Given this list of marker genes Rad21, Trim37, Hnrnpc (NCBI Gene Id 28125), Prdx2, Gsk3a, St3gal4, Kitl, Racgap1, S100a3, Mki67, Prim1, Prc1, Slc39a6, Nipbl, Ect2, Gas6, Vamp5, Snhg5, Nsmce4a, Fubp1, Amd1, Asf1b, Tfdp1, Grem2, Cdt1, Cmc4, Cpsf2, Rcl1, Luc7l3, Nucks1, Pspc1 (paraspeckle protein 1), Btbd1, Anapc5, Ahcyl, Smc3, Cenpk, Kif2c, Adsl, Cdca7l, Brip1os, Kif20a, Psip1, Cdca3, E2f8, Ptges3, Hmgb3, Epb41l4aos, Cdc45, Vcan, Hmgn2, Gclc (glutamate-cysteine ligase, catalytic subunit), Trim59, Id4, Ptgis, Dnph1, Hjurp, Iqgap3, Pclaf, Cks1b, Parp1, Birc5, Haus3, Ptprv, Ptma, Col6a3, Brca1, Rbbp4, Mre11a, Alad, Tsc22d1, Scoc, Mdm2, Aurka, Casp8ap2, E2f1 (E2F transcription factor 1), Gm3325, Hmgn1, Tmem106c, Hmga2 (high mobility group AT-hook 2), Cav1, Perp, Cbx5, Brca2, Ei24, Myh11, Tpgs2, Tk1, Anln, Dlgap5, Gm4870, Cenpa, Ppp5c, Nav2, Zmynd11, H2az1, Anapc11 (NCBI Gene Id 97770), Prrx2, Fignl1 (fidgetin-like 1), Hip1r, Cip2a, Cdk2, Dek, Crip2, Lmo7, Tubb5, Gmnn, Mad2l1, Rbmx, Prpf19, Smc2, Idh2, Sema3c (NCBI Gene Id 68696), Lsm3, Etfb, Tardbp, Pdia3, Tulp4, Garin5b, Orc6, Sfpq, Pabpc4, Tmpo, Kank3, Dctpp1, H19, Helb, Kif11 (kinesin family member 11), H2az2, Ptger4, Kpna2, Ephx1, Mir5136, Hat1, Igf1r, Rfc1, Set, Fbln1, Mcm7 (NCBI Gene Id 17220), Mis18bp1 (NCBI Gene Id 97807), Kif2a, Hypk (NCBI Gene Id 67693), Has1, Dtymk, Anp32b, Cd34, Cxcl1 (C-X-C motif chemokine ligand 1), Mcm5, Ccnf, Cse1l, Naa10, Tiparp, Wwtr1, Fam13b, Nqo1, Tipin, Hpf1, Erdr1, Ramp3, Dnajc9, Pradc1, Ipo5, Lsm4, Tnrc6a, Prl2c2, Kif4, Cck, Dohh, Ube2t, Arcn1, Otud4, Il1r1, Fas, Dlx1, Plk1, Bub1, Cbx6, Ifrd2, Mcm4, Ranbp1, Chaf1b, Ces2g, D17H6S56E-5, Cebpz, Klf10, Spdl1, Slc12a2, Cdc25c, Ogt, Rbl1, Kif23, Hspd1, Xpo1, Rfc5, Dstn, Ilf3, Cdc6 (cell division cycle 6), Hdac2, Ccnb2, Wac, Nop58, Ylpm1, Stmn1, Ereg, Lage3, Ckap2, Ube2s, Smad6, Cdkn3, Hnrnpr, Nek2, Sae1, Ccna2, H2ax, Rrm2, Penk, Kif22, Nap1l1, Smim11, Sass6, Topbp1, Ifi27, Mcm3, Gclm, Banf1, Pcna (proliferating cell nuclear antigen), Cks2, Trip13, Cdh2, Cdk1, Dtl, Rfc4, Srsf2, Pola1, Rad51, Cox6b2, Tgds, Nasp, Rad51ap1, Pimreg, Crabp1 (cellular retinoic acid binding protein I), Tyms, Nusap1, Timm8a1, Gm4739, here is a description of the gene set: Functional inactivation of the retinoblastoma tumor suppressor gene product (RB) is a common event in human cancers. Classically, RB functions to constrain cellular proliferation, and loss of RB is proposed to facilitate the hyperplastic proliferation associated with tumorigenesis. To understand the repertoire of regulatory processes governed by RB, two models of RB loss were utilized to perform microarray analysis. In murine embryonic fibroblasts harboring germline loss of RB, there was a striking deregulation of gene expression, wherein distinct biological pathways were altered. Specifically, genes involved in cell cycle control and classically associated with E2F-dependent gene regulation were upregulated via RB loss. In contrast, a program of gene expression associated with immune function and response to pathogens was significantly downregulated with the loss of RB. To determine the specific influence of RB loss during a defined period and without the possibility of developmental compensation as occurs in embryonic fibroblasts, a second system was employed wherein Rb was acutely knocked out in adult fibroblasts. This model confirmed the distinct regulation of cell cycle and immune modulatory genes through RB loss. Analyses of cis-elements supported the hypothesis that the majority of those genes upregulated with RB loss are regulated via the E2F family of transcription factors. In contrast, those genes whose expression was reduced with the loss of RB harbored different promoter elements. Consistent with these analyses, we found that disruption of E2F-binding function of RB was associated with the upregulation of gene expression. In contrast, cells harboring an RB mutant protein (RB-750F) that retains E2F-binding activity, but is specifically deficient in the association with LXCXE-containing proteins, failed to upregulate these same target genes. However, downregulation of genes involved in immune function was readily observed with disruption of the LXCXE-binding function of RB. Thus, these studies demonstrate that RB plays a significant role in both the positive and negative regulations of transcriptional programs and indicate that loss of RB has distinct biological effects related to both cell cycle control and immune function. from publication Markey MP, Bergseid J, Bosco EE, Stengel K, Xu H, Mayhew CN, Schwemberger SJ, Braden WA, Jiang Y, Babcock GF, Jegga AG, Aronow BJ, Reed MF, Wang JY, Knudsen ES (PMID 17452985) species: Mus musculus Mouse Gene Set: MARKEY_RB1_ACUTE_LOF_UP Genes up-regulated in adult fibroblasts with inactivated RB1 by Cre-lox: acute loss of function (LOF) of RB1.